Given this list of marker genes ARMT1, CPEB1, COL1A2, PCGF3, ENTPD7, ELP1, FGF11, NR6A1, SIGLEC5, PRPF38B, CNOT6L, STK40, DIP2A, C15orf39, PPP1R16B, PLXNC1, FAXC, ACTA1, LAMP2 (NCBI Gene Id 3920), PABIR1, TMC7, HAS2, GOLT1B (golgi transport 1B), TET3, MASP1 (MBL associated serine protease 1), AGO4, SLC5A6, GPR26 (G protein-coupled receptor 26), TRANK1, THOC2, HOXD1, COL3A1, PLPP5, RANBP2, FGD6, CEP135, WNT9B, PALD1, DPH3, RGS6, RSPO2, LIN28B, SESTD1, GNPTAB, SMC1A, HIP1, IMPG2, PLA2G3, STX3, TMEM121B, YPEL2, GJC1, RICTOR, KCNC2, HECTD2, CADM2, C19orf47, ADAMTS8, PRLR, CASP3, GALNT2, UTRN, RUFY3, GAS7, TTLL4, ZNF644, GDF6, AMT, GFM2, CDC34, XKR8, SNX30, GTF2I, ZNF512B, MYCN, DLC1, SCN4B, NME6, MFSD4A, HAND1, ZNF784, CLCN5, IL13, PRSS22, ABL2, DDI2, B3GNT7, THRSP, UHRF2, MTDH, INSR, ACSL6, IGF2BP2, MAPK6, TSPEAR, TMEM234, COL4A2, MDM4, DTX2, IGDCC4, ADRB3, PBX3, SLC25A27, PEX11B, SLC16A9, DNA2, SDK1, VAV3, LIMD2, NAP1L1, USP38, SLC20A1, RGS16, USP44, BEGAIN, ZFYVE26, IQCB1, DLST, FAM135A, ACER2, ZNF583, FIGNL2, LIPH, CPEB3, ZNF322, ATOSB, LBR, GYG2, CCNJ, KLF9, HDX, EPHA4, TMOD2, GAN, COL27A1, ZNF516, MEF2C, MAP4K3, SENP5, SLF2, PLEKHO1, DUSP22, RAB11FIP4, COIL, LPGAT1, BACH1, COL4A6, SEMA4G, CD59, SIGLEC14, CERT1, PBX2, SLC38A9, CNTRL, SALL4, MIB1, IGDCC3, ARK2C, ARHGEF38, RNF20, KIAA0930, DMD, GPCPD1, DTX4, AGAP1, ZBP1, TRIM67, NME4, ZNF689, C8orf58 (NCBI Gene Id 541565), LIN28A, SLC2A12, HMGA2, ADRB2, GALNT1, CERCAM, ATP8B4, PDE12, ARID3B, MED8, GALC, ACVR1C, CRTAM, ELF4, PGRMC1, DDTL, NGF (nerve growth factor), PLXND1, PLEKHA8, ZNF275, ABCC5, SPRYD4, NEK3, ZBTB5, PPP1R15B, ABCB9, TECPR2, PARPBP, SMIM3, RIMOC1, FIGN, LEPROTL1, RFX6 (regulatory factor X6), GPATCH2, IGF1R, DPP6, FASLG, STARD9, COL4A1, POLR3D, PIGA, GNG5, EDEM3 (NCBI Gene Id 87240), XRN1, PTPRD, SRGAP1, DNAJC1, PAPPA, XK, E2F6, ADAMTS15, HIF1AN, DVL3, HOOK1, VCF1, ERCC6, NIPAL4, CLDN16, TRMT13, HDLBP, ASAP1, UGCG, E2F2, OPA3, DHX57, RDX, AEN (apoptosis enhancing nuclease), AP1S1, CCL7, EFHD2, STARD3NL, ANKRA2, PRTG (protogenin), STIMATE, TBKBP1, CPA4, CDC25A, ATP2A2, ARID3A, DCUN1D2, PLAGL2, CDKN1A, ARHGAP28, ZCCHC9, DNAJA2, EIF4G2, POLL, SNX16, FNIP1, ACVR2A, AHCTF1, CEMIP2, ZSWIM5, CCND2, CCR7, KCTD17, FBXL12, MAP3K9, COL5A2, FRMD4B, TAF9B, GABBR2, FNIP2, WDR37, PDP2, CHD4, KLF8, ERCC4, OSMR, RAB8B, RBFOX2, TMEM167A, SLC22A23, MMS22L (NCBI Gene Id 253714), ONECUT2, KCNJ11, CPEB2 (NCBI Gene Id 285549), MAP3K1, EEF2K, MEIS2, TNFSF9, ERO1A, SOCS4, ZBTB8B, ARG2, NPHP3 (NCBI Gene Id 27031), KDM3A (lysine demethylase 3A), FNDC3B, AKAP6, CD164, MAPK8, PLPP6, SCN11A, APBB3, SLC31A2, PLEKHG6, SLC5A9, PXDN, RASGRP1, LINGO1, CEP120, CBX5, FZD3, YOD1, ITGB3, DDX19B, BZW1, POGLUT1, CLP1, SENP2, ENTREP2, PEG10, SALL3, NRAS, PTAFR, GATM, SKIL, PCDH19, CARNMT1, NYNRIN, KLHDC8B, ATL2, NHLRC3, MRS2, SLC35D2, TGFBR3, STARD13, TRIM71, MBD2, IRS2, HIC2, TMPPE, SFMBT1, VIRMA, KLHL31, EEA1, DNAAF9, SLC10A7, NKAPD1, LRIG3, HSPA14, SEMA4C, TMEM65, SUB1, ZNF710, GCNT4, DCAF15, BIN3, BEND4, PARP8, BSN, IGF2BP3, PDPR (NCBI Gene Id 55066), POGZ, ABT1, FNDC3A, ARL5A, AMOT, NPEPL1, SMARCAD1, DDX19A, B4GAT1, PIK3IP1, USP24, SRD5A3, C14orf28, FRAS1, PBX1, XYLT1, EDN1, KIAA1958 (NCBI Gene Id 377812), TGFBR1, LRIG2, KCTD21, TMPRSS2, DUSP1, TSEN34, PXT1, HOXA1, IGF2BP1, SCD (stearoyl-CoA desaturase), LIPT2, STRBP, OSBPL3, CLDN12, RALB, ZNF280B, MARS2, IKZF2, E2F5, ESR2, FZD4 (NCBI Gene Id 8322), GXYLT1, here is a description of the gene set: from publication Chen Y, Wang X (PMID 31504780) Genes predicted to be targets of miRBase v22 microRNA hsa-let-7f-5p in miRDB v6.0 with MirTarget v4 prediction scores > 80 (high confidence targets). studied in species Homo sapiens Human Gene Set: LET_7F_5P